The following is a description of a gene set: GAB1 is recruited to the activated EGFR indirectly, through GRB2. GAB1 acts as an adaptor protein that enables formation of an active PIK3, through recruitment of PIK3 regulatory subunit PIK3R1 (also known as PI3Kp85), which subsequently recruits PIK3 catalytic subunit PIK3CA (also known as PI3Kp110). PIK3, in complex with EGFR, GRB2 and GAB1, catalyzes phosphorylation of PIP2 and its conversion to PIP3, which leads to the activation of the AKT signaling. part of: Signaling by EGFR species: Homo sapiens Reactome Pathway: GAB1 signalosome, and this is the list of marker genes: EREG, CSK, PTPN11, PIK3R1, SRC, EGF, PXN, BTC, GRB2 (NCBI Gene Id 80715), EGFR, EPGN, PIK3CA, PAG1, HBEGF, GAB1, AREG, TGFA